The following is a description of a gene set: studied in species Mus musculus Mouse Gene Set: GOBP_NEGATIVE_REGULATION_OF_NEURAL_PRECURSOR_CELL_PROLIFERATION Any process that stops, prevents, or reduces the frequency, rate or extent of neural precursor cell proliferation., and this is the list of marker genes: Il1b, Nr2e1, Appl2 (NCBI Gene Id 216190), Ilk, Vsx2, Pde9a, Gata2, Lims1, Prox1 (NCBI Gene Id 320240), Spint2, Ctnna1, Fgfr3, Kdm2b, Btg2, Trp53, Kifap3, Vax1, Rapgef1, Pax6, Tgfb1, Shoc2, Kctd11, Ccr5, Cd24a, Wnt5a, Nf1, Lims2, Ptn, Slc6a4 (NCBI Gene Id 216958), Slc16a2, Bdnf, Spint1, Sirt2, Cend1